Given this list of marker genes YWHAQ, MCM3, MTHFD1, CD37, SMARCE1, TUBB4B (NCBI Gene Id 10383), HNRNPA2B1, ADCY9, ZWINT, FKBP3, RAD51, AURKB, CPS1, PLK1, TIA1, SOX9, TTK, CASP8AP2 (caspase 8 associated protein 2), GAMT, GTF2I, PTPN4, ANKH, LSM5, KPNA2, BARD1, HLTF (NCBI Gene Id 6596), ORC6, TUBB, CDC45, SFPQ, TRA2B, NUSAP1, SDC1, VRK1, HMMR, KIF20B, ORC1, KIF4A (NCBI Gene Id 55595), NFYB, CARHSP1, SIM2, SRSF6, GUCY1B1, DBP, RGS2, CHN1, MOK (MOK protein kinase), MAPRE2, HDAC1, TNS3, PDGFRB, CBX1, SNRPA1, CHST12, MEIS2, HSP90AA1, JPT1, MCM5, PRSS23, NME4, EBP, NUP107, MTF2, NDUFB3, SOX4, TMPO, CBFB, SMC4, NTHL1, NPEPPS, NRIP1, NARF, MAD2L1, MYCBP, TSPAN7, TUBG1 (tubulin gamma 1), PSMC3IP (PSMC3 interacting protein), ZNF107, TUBB2A, CBX3, TFE3, B4GALT5, AURKA, KIF2C, CHAF1A, MIPEP, KIF22, HNRNPM, DNMT1, B4GAT1, KIF20A, ZBTB33, DCK, VDAC3, FASN, ISYNA1, SNRPD1, PRDX3, RRM2, HNRNPR, RGS4 (regulator of G protein signaling 4), NR2F1, BFSP1, MED14, FOS, PLK4, CDC25B, FOXG1, EZH2, RFC3, ACACA, TCF4, RRM1, RFC4, KIF23, TLE2, PGAM1, USP1, MYLK, PRPS1, NDUFA2, SNRPF, CCNB2, HMG20B, CDC6, BRCA1, VAV3, NR4A2, NHERF1, RFC5, FOSB (NCBI Gene Id 2354), TPI1, MATN2, UBE2N, ZNF443, MYBL2, KPNB1, BRD3OS, EWSR1, POLE2, CDC7, PDCD2, SGPP1, OAZ2, GMNN, CDC25A, DDX23, SEMA5A (NCBI Gene Id 9037), PACSIN2, TOPBP1, BUB1, NPAT, TPX2, SRSF1, ATP5MC3, TFDP1, F2R, NPTX1, FZD2, MACROH2A1, CCL2, CCNE2, HSPB1, SLC25A10, TUBA1A, CYB5A, RFX5, E2F1, STIL, CRIP2, GREM1, VAMP1, MSH2, SKAP1, SLC39A8, PXMP2, CENPA, GINS2, NEK2, PRC1, SRP9, CENPF, DHX15, USP13, H2AZ2, POLD1 (NCBI Gene Id 5424), AKR1C1, TOP2B, PBK, CYP1B1, GPSM2, ENO1, CNN3, DHX9, PRIM1, COL1A1, DEK, CDK2AP1 (cyclin dependent kinase 2 associated protein 1), UPK1B, TIMELESS, ANP32A, RECQL4, CHEK1, RANBP1, CHAF1B, JUNB, CKB, MRE11, SRSF7, PTTG1, CRABP2, CDC25C, SUV39H1, IRS1, CDK2, LDHA, ITGB3BP, RNASEH2A, ID2, LIG1, DPYSL3, PRKDC, RAB40B, RBM14, PTTG3P, TROAP, DHCR24, LTBP3, SRSF3, CDC20, SRSF10, HIRIP3, MKI67, WWTR1, TRIP13, OPN3, KIF15, PARP1, NDC80, APC, RPA1, RPA3, SCG5, MRPL23, NUP50, COCH, ID1, CDK1, SPAG5 (NCBI Gene Id 10615), HS3ST3A1, FEN1, ITGB1BP1, UBE2E3, ABCC6, SKP2 (NCBI Gene Id 86997), TOP2A, PAFAH1B3, NCAPG (non-SMC condensin I complex subunit G), SLC27A2, PLS3, PLOD2, SRRT, GALNT2, MID1, MCCC2, LPCAT3, RBBP7, TACC3, UBE2C, ABCD3, CCNF, CSE1L, HSPA14, PIAS3 (protein inhibitor of activated STAT 3), DTYMK, SYNCRIP, FBXO5, PFKFB3, RAB4A, HMGB3, IQGAP2, SETMAR, POLA2, SMC1A, MCM6 (minichromosome maintenance complex component 6), ESPL1, EXO1, INCENP, POLE, DDR2, PIK3R3, TK1, CDKN3 (NCBI Gene Id 1033), SHMT1, DHFR, CKS2 (CDC28 protein kinase regulatory subunit 2), PKM, MCM2, STMN1, PDE4A, DGCR2, NASP, RFC2, BUB1B, POLA1, CCNA2, NNAT (NCBI Gene Id 4826), SPANXA1, ARPP19, GALNT1, TWSG1, SRSF2, CEMIP2, MSH6, KIF11 (kinesin family member 11), LMNA, SOX11, GTF3C2 (general transcription factor IIIC subunit 2), FANCA, TECR, MEST, HMGB1, DUT, SEPTIN9, CDKN2C, ENC1, PCNA, FNTB, HSPA2, ATP5MF, RIPK4, RBX1, RGS5, DDX39A, SMC2, DBR1, RAD51AP1, H2AZ1, CCND3, ACLY, TYMS, here is a description of the gene set: Selected genes down-regulated in response to the Ras inhibitor salirasib in a panel of cancer cell lines with constantly active HRAS. Human Gene Set: BLUM_RESPONSE_TO_SALIRASIB_DN from publication Blum R, Elkon R, Yaari S, Zundelevich A, Jacob-Hirsch J, Rechavi G, Shamir R, Kloog Y (PMID 17409441) studied in species Homo sapiens Deregulation of Ras pathways results in complex abnormalities of multiple signaling cascades that contribute to human malignancies. Ras is therefore considered an appropriate target for cancer therapy. In light of the complexity of the deregulated Ras pathway, it is important to decipher at the molecular level the response of cancer cells to Ras inhibitors that would reregulate it. In the present study, we used gene expression profiling as a robust method for the global dissection of gene expression alterations that resulted from treatment with the Ras inhibitor S-farnesylthiosalicylic acid (FTS; salirasib). Use of a ranking-based procedure, combined with functional analysis and promoter sequence analysis, enabled us to decipher the common and most prominent patterns of the transcriptional response of five different human cancer cell lines to FTS. Remarkably, the analysis identified a distinctive core transcriptional response to FTS that was common to all cancer cell lines tested. This signature fits well to a recently described deregulated Ras pathway signature that predicted sensitivity to FTS. Taken together, these studies provide strong support for the conclusion that FTS specifically reregulates defective Ras pathways in human tumor cells. Ras pathway reregulation by FTS was manifested by repression of E2F-regulated and NF-Y-regulated genes and of the transcription factor FOS (all of which control cell proliferation), repression of survivin expression (which blocks apoptosis), and induction of activating transcription factor-regulated and Bach2-regulated genes (which participate in translation and stress responses). Our results suggest that cancer patients with deregulated Ras pathway tumors might benefit from FTS treatment.